Given this list of marker genes ASPRV1 (NCBI Gene Id 151516), KRTCAP2, TNF, CD3E, PLEKHA1, STAU2, RBBP7, SERINC4 (NCBI Gene Id 619189), LUZP1, ANGPTL1 (angiopoietin like 1), P2RY14, GGACT, RSPH3, B4GALT3, MOS, UBOX5, MALAT1, HYOU1, SIGLEC7, ATXN1, OPHN1, LY75, CDRT4, ALPL, CDCP1, THRAP3, TBC1D8, TRIM26, GNAS, DELE1, SLFN13, BMP2K, DCTN4, POP7, SEMA3F, ZNF124, CHRNA4, MAU2, L3HYPDH, MBL2, MITF, ABCD2, EPX, PENK, PRKD1, NME2, UBLCP1, TMEM123, HIVEP1, EIF2S1, TAF11, COL5A1, EEF1B2, SLC25A20, SREK1, PCSK4, MED11 (NCBI Gene Id 400569), ACER1, RECQL5, TAAR1, FCGR2B, RBM10, B2M, TRIM33, PAXBP1, NCAPH2, GARS1, PRELID1, IL13, EDN2, BPGM, TJAP1, GABRB2, SUPV3L1, ZFP62, CDKAL1, DTX2, PPDPF, SLC16A6, ZMYM4, ATF7IP2, HLX, RAB40B, GNMT, CALCOCO2, HESX1 (NCBI Gene Id 8820), RLN1, ELOC, HSPA5, LAMA3 (NCBI Gene Id 3909), ELOVL3, ARGLU1, GLI3, SSTR1, KCNMB1, CPA3, CST3, PARD6A, GTF2E2, FABP2 (NCBI Gene Id 2169), ZBTB2, GCNT3, MRPS15, SCIN, PCBD1, FOXP1, NDP, WASF1, CALB1, MAP2K6, RAD51B, CXCL2, CCDC198, OTC, ENAM, YIPF7, TNP1, CFLAR, DPEP3, N4BP1, NFIL3, MMP23B, ENPP1, C1QBP, CA11, DENND2B, NAA38, JMJD6, TBC1D14, CRABP2, NHERF1, KDM5C, PIP5K1B, PDE4B, CORO2B, KRT8, XRN2, TMEM119, TRPS1, LYST, FSCN1, SHOX2, INHBB, RDH14, TRAT1, YPEL1, RB1CC1, C1orf174, ANXA8, MOBP, TAX1BP3, SERPINB2, POP4, PPP1R2P1, NPAS1, CDH3, PTPRN2, GZMM, SLC2A1, TRIB2, PROM1, ACTN1, UTY, KRT35, REM2, GNPAT, SPP1, FOXI1, OGA, AMPD2, LIMA1, ATP10A, CPD, HCFC1R1, CXCL10, SP4, ZBTB20, CDH9, PSCA, KCND1, DDX5, STAB2, ZC3H12C, SPRY4, CIZ1, CATSPERG, BCL7C, MAP2K1, TAF1C, ASH1L, SOCS2, CEBPZ, WNT10B, ZNF212, CCNL1, ACTG1, ATP1B2, GDF9, RND3, here is a description of the gene set: studied in species Homo sapiens from publication Amit I, Garber M, Chevrier N, Leite AP, Donner Y, Eisenhaure T, Guttman M, Grenier JK, Li W, Zuk O, Schubert LA, Birditt B, Shay T, Goren A, Zhang X, Smith Z, Deering R, McDonald RC, Cabili M, Bernstein BE, Rinn JL, Meissner A, Root DE, Hacohen N, Regev A (PMID 19729616) mouse primary BMDCs were stimulated with tlr ligands and gene expression changes were profiled on Affymetrix arrays Human Gene Set: GSE17721_CTRL_VS_POLYIC_1H_BMDC_DN Genes down-regulated in comparison of control dendritic cells (DC) at 1 h versus those stimulated with poly(I:C) (TLR3 agonist) at 1 h.